Given this list of marker genes Grik5, Eml1, Hbs1l, Tnni3k, Lin9, Pde1a, Rbms3, Prkce, Cyp4a14, Nt5c2, Dagla, Atp6v1g1, AA467197, Wnt3a, Mtbp, 2510009E07Rik, Zfp958, Wwtr1, Zfp1009, Ikbip, Pgam5, Eif4b, Vps54, Crispld2, Dscaml1, Ebf2, Scoc, Ifi211, Atp6v1a, Samd13, Bptf, Zfp563, Kcnk10, Zfp407, Fam161b, Klf15, Slc4a10, Atg12, Pex12, Adgrg6, Gpr180, Nrp1, Slc7a12, Itgb5, Rab5b, Mndal, Gpc6, Pabpc5, Akap7, Ago2, Brwd1, Enox2, Rapgefl1, Pramel17, Serinc5, Chd9, Grik2, Ppp1r10, Eif4a1, Zfp955b, Slitrk6, Slc12a1, Grpel2, Hycc2, Rwdd4a, Cdc14a (NCBI Gene Id 229776), Pdia6 (protein disulfide isomerase associated 6), 2410004B18Rik, Hdx, Ifi205, Lama5, Cenpw, Sftpb, Tmem35b, Fam98a, Gpr146, Slc8a1, Hnrnpa0, Pank2, Med1, Rbms1, Fgd5, Kpna4, Fbxo11, Bend4, Zfp607b, Zfp719, Casp12, Gramd2b, Sidt2, Prkd1 (NCBI Gene Id 18760), Nktr, Spta1, Arhgap42, Lamc1, Msl3, Caprin1, 9530068E07Rik, Ccdc148, here is a description of the gene set: species: Mus musculus from publication Chen Y, Wang X (PMID 31504780) Mouse Gene Set: MIR_376B_3P Genes predicted to be targets of miRBase v22 microRNA mmu_miR_376b_3p in miRDB v6.0 with MirTarget v4 prediction scores > 80 (high confidence targets).